Given this list of marker genes GRIN2A, MIRLET7F1 (microRNA let-7f-1), CASP4, GRM5, IGF1, BACE1, MIR106B, EPHB2, AGER, ADRB2, MIR140, GSK3B, FPR2, TREM2, FCGR2B, GRIN1, SNX6, MIR200A, LRP1, CD36, LGMN, IGF1R, EPHA4, ATP1A3, VCAM1, TLR6, CACNA1A, APP, MIR146A, CACNA2D1, GJA1, MIR98, LCN2, CDK5, FOXO3, SYK, TYROBP, ABCC1, TNF, CACNB1, TLR4, NGFR (NCBI Gene Id 4804), ITGA4, PSEN1, FYN, ICAM1, PARP1, PRNP, NTRK1, here is a description of the gene set: Human Gene Set: GOBP_CELLULAR_RESPONSE_TO_AMYLOID_BETA studied in species Homo sapiens Any process that results in a change in state or activity of a cell (in terms of movement, secretion, enzyme production, gene expression, etc.) as a result of a amyloid-beta stimulus.